The following is a description of a gene set: Mouse Gene Set: GOMF_SULFURIC_ESTER_HYDROLASE_ACTIVITY Catalysis of the reaction: RSO-R' + H2O = RSOOH + R'H. This reaction is the hydrolysis of a sulfuric ester bond, an ester formed from sulfuric acid, O=SO(OH)2. studied in species Mus musculus, and this is the list of marker genes: Arsb, Sts, Sulf2, Arsi, Gns, Arsa, Ids (iduronate 2-sulfatase), Sgsh, Arsj, Arsg, Galns, Sulf1, Arsk